Given this list of marker genes Rpgrip1l, Crocc, Klc2, App (NCBI Gene Id 319425), Nek4, Kif5a, Rab28, Pjvk, Rpgrip1, Psen1, Klc1, Kif5c, Odad3, Spag5, Kif5b, Klc3, here is a description of the gene set: Mouse Gene Set: GOCC_CILIARY_ROOTLET species: Mus musculus A cytoskeleton-like structure, originating from the basal body at the proximal end of a cilium, and extending proximally toward the cell nucleus. Rootlets are typically 80-100 nm in diameter and contain cross striae distributed at regular intervals of approximately 55-70 nm.